The following is a description of a gene set: In contrary to the vesicle-mediated macroautophagy, the chaperone mediated mechanism of autophagy selectively targets individual proteins to the lysosome for degradation. Chaperones bind intracellular proteins based on recognition motifs and transports them from the cytosol to the lysosomal membrane. Subsequently, the protein is translocated into the lumen for digestion (Cuervo A M et al. 2014, Kaushik S et al. 2018). part of: Autophagy Reactome Pathway: Chaperone Mediated Autophagy species: Homo sapiens, and this is the list of marker genes: RPS27A, HDAC6, LAMP2 (lysosomal associated membrane protein 2), EEF1A1, ARL13B, UBB, UBA52, CFTR, HSP90AA1 (heat shock protein 90 alpha family class A member 1), RNASE1, CETN1, PCNT (NCBI Gene Id 9346), PLIN3, PLIN2, HSP90AB1, IFT88, HSPA8, PARK7, HBB, GFAP, VIM, UBC